The following is a description of a gene set: Amaurosis fugax A transient visual disturbance that is typically caused by a circulatory, ocular or neurological underlying condition. studied in species Homo sapiens Human Gene Set: HP_AMAUROSIS_FUGAX, and this is the list of marker genes: PIK3CA, POLD1, MPL, TET2, EPCAM, PMS2, MSH2, MARCHF6, HLA-B, CHEK2, MSH6, CALR, TP53, IL12B, TGFBR2, SEMA4A, MUTYH (NCBI Gene Id 4595), ADA2, ADRA2B, CNTN2, SCN1A, ATM, KRAS, POLE, HLA-DRB1 (major histocompatibility complex, class II, DR beta 1), ATP1A2, SAMD12, JAK2, YEATS2, PTPN22, MLH1, RPS20, PRRT2 (NCBI Gene Id 81865), PMS1, P4HA2, BMPR1A, BRCA2, SH2B3, CTNND2, CACNA1A, MLX